The following is a description of a gene set: studied in species Homo sapiens Neighborhood of VAV1 Human Gene Set: GNF2_VAV1 Neighborhood of VAV1 vav 1 oncogene in the GNF2 expression compendium, and this is the list of marker genes: VAV1, TRIM38, RAC2, ELF4, HLA-F, GIT2, CORO1A, HLA-C, HLA-E, CORO7, ARHGDIB, SP110, TRIM22, WAS, CYBA (cytochrome b-245 alpha chain), ACTR2 (NCBI Gene Id 10097), STAT6, DOCK2, HCLS1, GRK6, CSK, HLA-G, PAK2, CYTIP, PTPRC, SASH3, CD53, GPSM3, HLA-B, PIK3CD, LAPTM5, PSMB10, CD48, PHF11, OSTF1, INPP5D